Given this list of marker genes Calm1, Ppp3r1, here is a description of the gene set: Reactome Pathway: CLEC7A (Dectin-1) induces NFAT activation This event has been computationally inferred from an event that has been demonstrated in another species.<p>The inference is based on the homology mapping from PANTHER. Briefly, reactions for which all involved PhysicalEntities (in input, output and catalyst) have a mapped orthologue/paralogue (for complexes at least 75% of components must have a mapping) are inferred to the other species. studied in species Mus musculus electronically inferred by orthology from the curated human pathway part of: CLEC7A (Dectin-1) signaling